The following is a description of a gene set: species: Mus musculus Mouse Gene Set: GOBP_REGULATION_OF_OOCYTE_MATURATION Any process that modulates the frequency, rate or extent of oocyte maturation., and this is the list of marker genes: Shb, Grb14, Bnc1, Aurka, Nppc, Sirt2, Npr2, Wee2